Given this list of marker genes AVL9, PLIN5, HLA-B, SLFN13, TRNT1, SERTAD3, INPP1, GRK1, ZNF689, ITK, TRIM26 (NCBI Gene Id 7726), B2M, IL11, CHMP4B, PNPT1 (NCBI Gene Id 87178), PATJ, UBE2D1, TRAFD1, TAPBP, PARP14, PPIC, AGRN, MTFMT, RTP4, RBM43, ATG4B, STAT1, WTAP, NIF3L1, RAB3IP, SELL, ST6GALNAC5, PIK3C3, SLC25A28, SAMHD1, NRG3, RCL1, TOR1AIP2, SS18, TMTC4, DAXX, OAS3, ZEB1, PARP9, RSAD2 (radical S-adenosyl methionine domain containing 2), ISG20, PCCA, KBTBD2, TASOR2, TXK, PELI1, TRIM21, RGS10, IRF7, HLA-G, WDR43, PSMB9, TLR7, N4BP1, ANKFY1, RIPK1, FNBP4, CASP8, GPSM2, CMPK2, PSMB10, MX1, CCRL2, RAB29, VPS54, CRBN, PML, RBBP9, CMTM6, NMI, HK1, IRF9, EIF2AK2, TRAF3IP2, NSUN4, IGDCC3, CD274, GBP2, ISOC1, NOTCH1, DICER1, IFI27L2, ETNK1, TOR3A, DCAF11, RAD51AP1, TMEM140 (transmembrane protein 140), OAS1, SHFL, DHX58, DDHD1, NME6, BST2, IFI44 (NCBI Gene Id 10561), PPA1, OASL, CASP2, GBP7, MAP2K1, MAP7, IRGM, CD164, B3GNT2, CMTR1, ACRBP, ASB13, S100G, NUB1, GOLGA3, CFAP418, APOBEC3B, PDK1, CAPN15, GBP6, RBL1, TAP1, TREX1, KEAP1, ATP11B (NCBI Gene Id 348830), SLFN12L, LIPA, ULK2, OGFR, TDRP, C19orf12 (NCBI Gene Id 83636), LGALS8, UBR2, RNF114, CNP, TLR4, RAPGEF6 (Rap guanine nucleotide exchange factor 6), IFI35, MITD1, ADAR, DDX24 (NCBI Gene Id 57062), HOOK2, FBXO38, SECISBP2, MX2, PNPLA7, RNF14, CNNM4, SESN3 (NCBI Gene Id 143686, sestrin 3), GBP4, ISG15, FAM111A, ZBP1, NAA20, RNF135, PSME2, DOP1B, NOC4L, AIDA, PMEPA1, USP18, TEX2, IFIH1, TDRD7, PEX26, IFIT3, LAPTM4A, STAT2, IRF1, DDX60, CXCL10, NAMPT, TNFSF10, PSMB8, CRLF3, LGALS9B, SSBP2, ZNFX1, TMEM184B, FEZ2, TRIM34, IFIT1B, MOV10, HLA-E, PSME1, RPL13, TBRG1, OAS2, PHLPP1, MORC3, TOR1AIP1, SCNN1B, PIGA, ST7, PARP12, KIF1B, ZUP1, IFIT2, LGALS3BP, HELZ2, TRIM25, here is a description of the gene set: Genes up-regulated in T reg: untreated ADORA2A knockout versus wildtype treated by ZM 241385. from publication Kinsey GR, Huang L, Jaworska K, Khutsishvili K, Becker DA, Ye H, Lobo PI, Okusa MD (PMID 22835488) Human Gene Set: GSE34006_A2AR_KO_VS_A2AR_AGONIST_TREATED_TREG_UP species: Homo sapiens The adenosine 2A receptor (A2AR) is expressed on regulatory T cells (Tregs), but the functional significance is currently unknown. We compared the gene expression between wild-type (WT) and A2AR knockout (KO) Tregs and between WT Tregs treated with vehicle or a selective A2AR agonist.